The following is a description of a gene set: Mouse Gene Set: GOBP_REGULATION_OF_STEROID_METABOLIC_PROCESS Any process that modulates the frequency, rate or extent of the chemical reactions and pathways involving steroids. species: Mus musculus, and this is the list of marker genes: Fdps, Bmp5, Gfi1, Apoe, Stub1, Erlin2, Abcb11, Sirt1, Gpr146, Insig1, Pex2, Prkg1, Bglap2, Qki, Acadl, Bmp2, Ephx2, Ces1c, Sec14l2, Igf2, Aqp8, Srebf1, Npy1r, Fmo5, Snai2, Prkaca, Nr3c1, Stard4, Adora2b, Hsd3b9, Abcg1, Cyp17a1, Cga, Abcg4, Lep, Cyp7a1, Atp1a1, Scap, Ttc39d, Rest, Clcn2, Hsd3b5, Mbtps2, Wnt4, Tspo, Armc5, Snai1, Akr1c18, Ifng, Dkk3, Ppargc1a, Scp2, Ces1b, Prox1, Dab2, Ces1h, Fgf15, Pde8b, Nr0b1 (NCBI Gene Id 11614), Ces1g, Bmp6, Tnf, Bglap, Kit (NCBI Gene Id 16590), Idi2, Hrh1, Apoa1, Srebf2, Egr1, Gh, Thrb (thyroid hormone receptor beta), Gnb3, Malrd1, Erlin1, Gnai1, Hsd3b8, Dhh, Star, Cyp27b1, Fshb, Igf1r, Creb1, Ttc39b, Nr5a2, Insig2 (NCBI Gene Id 72999), Mapk1, Stat5a, Gprc6a, Ldlr (low density lipoprotein receptor), Ces1a, Ces1d, Igfbp7, Igf1, Lhcgr, Il1a, Abca2, Asah1, Nfkb1, Ch25h, Cmtm2a, Hsd3b4, Arv1, Apob, Nr1d1, Gal, Serpina12, Rorc, Rora, Por, Dgkq, Acadvl, Dgat2, Dkkl1, Stat5b, Ces1e, Dhcr7, Kcnma1, Ces1f, Pank2, Foxa2, Lpcat3, H6pd, Lmf1, Ddx20, Paqr3, 3110082I17Rik (RIKEN cDNA 3110082I17 gene), Sod1, Sf1, Fgf1, Ggcx (NCBI Gene Id 56316), Fgfr4